Given this list of marker genes HOXA3, MGST1, ABHD1, KDM6B, SREBF2, ANXA1, GANC, RPS19, MYCBP2, HIBCH, TGIF1, EMC9, ALG14, TST, PFKFB1, LRP6 (NCBI Gene Id 4040), CRYZL1, KLHL25, SELENOP, REEP6, ATG12, NDUFS6, LAMC1, ZDHHC3, TMEM33, EXOC6 (exocyst complex component 6), HIC2, CCDC134, SPG21 (SPG21 abhydrolase domain containing, maspardin), SLC25A25, MAPKBP1, PEX14, GFER, ATP1B3, NUP85, USP5, BAZ1B, SLC1A5, PSPC1, NDUFS4, TMEM131, NFE2L1, HOXC8, CSPG4, MPP7, DNAJC5B, CCDC85B, TMEM120A, RABEP1, PROC, EHMT2, SLC5A6, HSP90B1, STAMBPL1, ACOT8, EPHX2, ASAH1, KIAA2013, MRPL10 (NCBI Gene Id 65004), SLC38A7, TTYH2, UTP3, TMCO4, PEX16, PDHA1, LONP2, INCENP, EPB41L2, EARS2, GINM1, PSMD4, ZNF740, LAMA4, QKI, SF1, ILRUN, NDUFS8, FMR1, MLKL, PPDPF, IMPDH1, LZTS2, IL17RC, SPATA6L, MAMDC4, MOB1A, SNN, DUSP13B, CAPN3, MCM7, OST4, ARRDC2, ST3GAL2, FABP4, SNRPD3, SPAAR, PALM2AKAP2, STOM (stomatin), SELENOK, ZMYND8, TANK, CARTPT, PLIN1, NCBP1, CSNK1G2, FLAD1, TXLNG, GABPA, SCAF1, ACADL, PNPLA8, SAMD4A, PHYHIPL, NFIB, POLN, TPMT, COG4, ARID5B, MARS1, ZNF486, CA4, TMEM168, PPP2CA, MSMO1, CHCHD3, EEF1E1, MSRA, FNDC3B, ACOX1, CHIC2, PTGR2, HMOX1, DNAJC19, AGPAT2, RMDN3, TXNIP, C11orf54, TAF1D, TP53I13, LMNA, RIPOR1, KAT2B, H4C8, GPT, DAB2IP, PYM1, ACYP2, TRAF3IP2 (TRAF3 interacting protein 2), CALCOCO1, PNRC1, EEIG1, H2AX, GHITM (growth hormone inducible transmembrane protein), RBMS1, KAT7, MLF2, ETFB (NCBI Gene Id 2109), TBCD, MOCS2, TCF7L2, MXD1, ABHD15, DRC3, SEMA4A, HSD11B2, COQ8A, UCHL3, NEURL4, TRIT1, MRPS33, CMA1, SUCLG1, CERK, ZBTB32, HAUS3, ZCRB1, AP5S1, NDEL1, SLC66A3, VPS26C, USP53, SNX33, RASSF6, FAM3C, ECHDC1, BSG, SNX10, TRAF7, ADAT2, PDGFRL, ESRRA, TMEM134, SLC45A4, ADIPOR2, ELMOD3, MRE11, NPHP3, ADCY6 (NCBI Gene Id 23320), ACADM (acyl-CoA dehydrogenase medium chain), PKD2L1, PPP1R15B, RPS2, LGALS3BP, HDGFL2, INPP1, PPP2R2A, N4BP3, RBCK1, DDIT3, AKT1S1, ATN1, ACADVL, ELMOD2, TNIP1, PRX, EHBP1L1, UBP1, STAT1, CERS4, CPSF4L, MBD6, LRRC8D, SLC2A4, RBM43, CAPN2, UBE4B, RRP1B (NCBI Gene Id 23076), MUSTN1 (musculoskeletal, embryonic nuclear protein 1), EFR3A, CD36, GLO1 (NCBI Gene Id 2739), G6PC3, REEP5, CNKSR3, IL17RB, BAZ2A, NABP1, RNF5, PNPLA2, ADCK2, LPL, CDKN1A, NR1D1, MYO1C, CES1, TIPARP, AMHR2, PCK1, H2AC18, SEC24C, CAMK1, MKX, ZNF93, CANX, IL2RA, SPATC1, EDC3, SSPN, UBFD1, ILVBL (ilvB acetolactate synthase like), ETFRF1, CHUK, C2orf76, DEDD, ENOX1, PROX2, CMSS1, ZRANB3 (NCBI Gene Id 84083), HYAL2, IRF2BPL, GUCD1, UBQLN1, LTBP3, TBXAS1 (thromboxane A synthase 1), ATRAID, TMCC3, ANKRD33, SYNGR4, STAT5A (signal transducer and activator of transcription 5A), EMILIN1, GTPBP3, STK3, IL13, HADH, ETV3, PUS10, POLR3H, NEK6, YWHAB, H3C14, EPPK1, AGPAT1, CS, RGS19, H2BC13, AGRP, CLEC10A, FAM13C, FNIP1, EMC6, AMDHD2, COQ5, ZNF32, SETD5, ATAT1, SLC25A46, SEC24B, ANXA7, SIGLEC1, ECH1, BET1, GGNBP2 (NCBI Gene Id 84160), ARHGAP29, ZCCHC7, PRKCI, STAT6, KMT2B, SCOC, CASP8 (caspase 8), QDPR, MTCH2, KCNK7, ADCK5, ATF1, CYB5A, LARGE2, ODAD3, PDGFRA, CTNNBL1, GPD1, ALAD, PHOSPHO2, DENND4B, RRP9, GNAI2, TXNDC12, PEX2, RNF6, IFRD1, ELAVL1, SORT1, ABCD3, WDR18, PDPK1, RHBDF1, UPP2, LOXL1, STK40, RANBP2, NPC1, AGBL5, SF3B3, CDK13, KBTBD12, HSD17B12, ACO2, PEX10, PEX3, TOMM40, CIMIP2A, BCAT2, CHPT1, ZGPAT, PDE12, CCDC50, MRPL36, S100A1, ZNF595, PREB, TUBB4B, CAV2, PPARG, PSMA5, COQ3, PIGX, ZSWIM3, DNAJC28, ZNF136, DCST1, GADD45A, FADD, NUDT12, ARMC8, MKLN1, ATP6V0C, FTH1 (ferritin heavy chain 1), MSTO1, PLOD3, NET1, TLE1, LGALS7 (galectin 7), UNK (unk zinc finger), PHPT1, UBR5, TOM1L2, ZNF219, THOC6, MMD, PTTG1IP, C11orf86, HOXA4, PRNP, EIF4EBP2, SMYD3, PAOX, DLST, ECHS1, MYL12A, HNRNPF (heterogeneous nuclear ribonucleoprotein F), DAP, LRRC41, SLC26A6, CAPN9, UCP2, LETMD1, TBL2, ASB15, HPGD, LNPEP (leucyl and cystinyl aminopeptidase), LMBR1, NLRP4, TMEM150A, KIAA0825 (NCBI Gene Id 401202), CEP44, CFAP210, KSR1, NOXO1, TIA1, ABCB8, YAP1, UTP6, SRSF4, MYLK, RIPK3, ATP5MC3, CLCN2, PEX5, IBA57, TMEM216, PLA2G15, S100A13, CLN3, THRSP (NCBI Gene Id 82916), FDX1, AP3S1, TNFAIP2, GSK3A (glycogen synthase kinase 3 alpha), DDO, NAAA, CRACR2B, RBM4B, AZIN1, SAMD8, SIVA1, CAVIN1, EEF2 (eukaryotic translation elongation factor 2), PANK3, B3GNT4, PHF5A, COX8BP, BAHCC1, LSM12, GRHL1, DERL1, IL34, PPIP5K1, MTDH, CAST, PCSK4, UFSP2, CEP19, GSTO1, LIME1, DLG4, PLPP6, MSH4, CREB3L4, TAF15, LUZP1, HJURP, EIF4G3, H3C15, EIF1AY, EBF2, TRAK1, FGF2, ATG101, MYD88, GIGYF2, SLC38A10, GAPDH, DYNLRB1, PLA2G6, ABCC4, CCDC80, DPP3, SYPL1, POLE, NMT1, PAN2, NIT1, FITM2, PPM1K, LSM10, CIDEC, FADS2, PLAAT3, RRAS, ETFA, ISOC2, PCCA, UCK1, NKAPL, EVI5L, FAM13A, ADIPOQ, TMEM143, SHC1, UBXN6, ACADS, DLC1, ZNF326, GSN, TARBP2, IFT70A (intraflagellar transport 70A), ZNHIT1, GPAT4, CCL1, CENPK (NCBI Gene Id 64105), STARD13, AOX1, POLD4, ASPA, ATXN10, DGKA (diacylglycerol kinase alpha), MARCHF5, BNIP3L, QTRT2, AP4M1, ECI2, MLST8, BTF3L4, ADIG, IDH3A, ZNF768, ATP5PF, SEC22C, DNAJC15, GPRC5B, ACAA1, SIPA1L1, RARRES2, CPA5, TEAD4 (TEA domain transcription factor 4), PRKCSH (PRKCSH beta subunit of glucosidase II), R3HDM1, PITPNM1, LIM2, SLC19A2, EIF4EBP1, PCYOX1, SCD, CENPI, LGALS12, MGAT4B, HIBADH, ALDH6A1, ATOSA, HCFC1, RBM12, RNFT1, G3BP2 (G3BP stress granule assembly factor 2), CYRIB, UTP14A, RMND5A, BBS12, CMPK1, PDIA4, ABI1, ZFYVE21, IL15RA, EIF4ENIF1, MBNL1, ZNF770, ABHD12, TALDO1, AMER1, MTARC1, H2BC11, CPNE1, FBXO31, WDR45, KIAA0232, MPRIP, ACAA2, ABCB9, TMEM254, HOXA1, BCL6, STAG1, JAGN1, APMAP, UBXN8, GARS1, MAL2, CCDC87, IFT70B, YPEL5, MRAP, LIF, ADTRP, ATG9B, WHAMM, MTUS1, PRXL2A, PIMREG, RTF2, ZNF429, ELF3, CPT1A, LIPE (NCBI Gene Id 3991), GNPNAT1, ZMYND12, HSDL2, HIVEP3, ETFDH, SLC25A10, CHP1, FBXO8, PRP4K, LRRC39, RNASET2, SLC25A39, CDC25A, GAS2L2, AIFM2, TOR4A, ANKRD46, NR2F2, UBL5, SELENOI, FAM9A (family with sequence similarity 9 member A), BTD, CFAP96, LIPT1, IFNGR1, TEF, EMC2, TBC1D15, TPT1, PEX11G, SLC35B4, ZNF655, CD99L2, CCNG2, STIMATE, TMEM87A, HSD11B1, RAB9A, PARL, OXSR1, UQCRH (NCBI Gene Id 7388), BCAR1, TBC1D13 (TBC1 domain family member 13), TOMM70 (translocase of outer mitochondrial membrane 70), KAT14, YWHAG (NCBI Gene Id 96443), GPR152, RIOK3, PBX2, FIBP, NTN1, OTUD5, NIPBL, IL31RA, TNPO3, KLF11, FAH, STT3B, CPEB3, CD302, PAM16, XRCC3, PTPN6, SNCG (synuclein gamma), CEPT1, TAX1BP3, NID1, PRKRA, HIPK1, USP6NL, CISH, TMEM140, TEX19, NR2F1, LDHB, CBLB, SP2, HNRNPL, ARHGEF37, ZFAT, SERPINE1, COX14, AFTPH, SEC24D, KLF15, GCSH, KDM1B, CKS1B, HCFC1R1, BMP2K, ERP29, CST3, LMBRD1, SLC48A1, TMEM116, MPST, SNAI3, GRPEL1, TTL, TCAF1, ITPRIP, ESYT1, ZEB2, TMT1B, IMMT (inner membrane mitochondrial protein), MAP3K12, NDUFC2, PLEKHF2, ARF4, TSGA10 (testis specific 10), SPECC1L, NUP188, SLC22A12, CALU, NEGR1, BCAR3, TMEM259, PLCB1, TRMT44, MINK1, GAB2, SCARB2, PDP2, GID4, PCBP2, POLR2H, TMEM175, UPB1, PTP4A2, FNDC8, KTI12, UCP1, TRAF2, BFAR, BUB1B, MMRN2, ACSL3, ECE1, RPN1, LIMK2, CSNK1D, MYL4, DRAM2, BCL2L13, C12orf57, GSTT3P, ATPAF2, NDUFA5, UBD, METTL9, NAT10, PEX11A, SLC39A13, ZDHHC18, PTBP1, OPLAH, CSAD, H2BC4, POU6F1, ADHFE1, LTC4S, SYCP2, XDH, TMED5, RNPEP, TOB2, S100A3, FBXL12, KMT5A, RACK1, COL4A1, EXD1, TNS2, PPWD1, CYTH1, TRAPPC5, ZBTB38, MID1IP1 (MID1 interacting protein 1), IDH1, IGSF6, CCDC18, NFKBIZ, CDC27, PXMP4, PPP1R3C, NATD1, ITSN1, ARFRP1, ORC5, RAB19, ZBTB14, PLOD1, CRTC2, MND1, SPRING1, CDCA3, ANGPTL4, DUSP19, PPCS, MDM2, ADAM1B, PIM3, CMBL, GABARAPL1 (NCBI Gene Id 23710), SLC37A3, HGH1, NR1H3, LENEP, GANAB, SLC5A7, SFXN1, LDLRAD3, DGAT1, ASPH, RNF4, EFNA5, HSPA5, ORMDL3, RASA3, CEP120, PLAC9, MPC2, GOSR1, TSPAN12, CREB3L2, H1-8, TENM4, MKNK2, CD53, PPHLN1, CALHM6, SCTR, TTC41P, CD151, PFKL (phosphofructokinase, liver type), LIN52, ADAMTS12, BCL2L10, PARP3, SH3GLB1 (NCBI Gene Id 51100), PPM1B, PXMP2, TXLNA, LMNTD1, SNAI2, HACL1, PC, here is a description of the gene set: Control of cell differentiation occurs through transcriptional mechanisms and through epigenetic modification. Using a chromatin immunoprecipitation-on-chip approach, we performed a genome-wide search for target genes of peroxisome proliferator-activated receptor gamma (PPAR gamma) and its partner protein retinoid X receptor alpha during adipogenesis. We show that these two receptors target several genes that encode histone lysine methyltransferase SET domain proteins. The histone H4 Lys 20 (H4K20) monomethyltransferase PR-Set7/Setd8 gene is upregulated by PPAR gamma during adipogenesis, and the knockdown of PR-Set7/Setd8 suppressed adipogenesis. Intriguingly, monomethylated H4K20 (H4K20me1) levels are robustly increased toward the end of differentiation. PR-Set7/Setd8 positively regulates the expression of PPAR gamma and its targets through H4K20 monomethylation. Furthermore, the activation of PPAR gamma transcriptional activity leads to the induction of H4K20me1 modification of PPAR gamma and its targets and thereby promotes adipogenesis. We also show that PPAR gamma targets PPAR gamma2 and promotes its gene expression through H4K20 monomethylation. Our results connect transcriptional regulation and epigenetic chromatin modulation through H4K20 monomethylation during adipogenesis through a feedback loop. studied in species Mus musculus Genes with promoters bound by both PPARG and RXRA at 8 day time point of adipocyte differentiation of 3T3-L1 cells (preadipocyte). from publication Wakabayashi K, Okamura M, Tsutsumi S, Nishikawa NS, Tanaka T, Sakakibara I, Kitakami J, Ihara S, Hashimoto Y, Hamakubo T, Kodama T, Aburatani H, Sakai J (PMID 19414603) Human Gene Set: WAKABAYASHI_ADIPOGENESIS_PPARG_RXRA_BOUND_8D